The following is a description of a gene set: 267 prognostically relevant Mitochondria-related genes associated with endometrial cancer from publication Lin X, Zheng J, Li Y, Liu L, Liu Q, Lin J, Sun Y (PMID 40354443) Human Gene Set: LIN_ENDOMETRIAL_CANCER_MITOCHONDRIAL_SIGNATURE Mitochondria are essential organelles involved in cell metabolism and are closely linked to various metabolic disorders. In this study, the authors aimed to develop a prognostic model for endometrial cancer (EC) patients based on mitochondria-related genes (MRGs), and to investigate the role of MACC1 in EC. As shown in the graphic summary, the authors retrieved gene expression and clinical data from open-access databases. To construct a predictive signature, the authors applied the Lasso Cox regression algorithm to MRGs. The predictive performance, immune features, and anti-tumor response of the mitochondrial signature was evaluated through multiple algorithms. Additionally, expression levels of key genes were validated using quantitative Real-Time PCR and Western Blot. A total of 2030 MRGs were retrieved, and 267 were found to be prognostically relevant. Eight MRGs MACC1, CMPK2, NDUFAF6, DUSP18, TOMM40L, MT-TP, SAMM50, and MAIP1 were identified to construct a prognostic signature for EC. The MRG signature demonstrated significant associations with drug sensitivity, immune therapy, and immune cell infiltration. Based on comprehensive bioinformatic analysis, MACC1 was identified as the most promising MRG candidate in EC. Systematic experimental validation, including both in vitro and in vivo approaches, demonstrated that MACC1 down-regulation significantly suppressed EC progression, highlighting its potential as a therapeutic target. species: Homo sapiens, and this is the list of marker genes: BCL2A1, TRMT10C, KRAS, SCO2, HSD17B4, IMMT, KIF1B, TIMM50, DUSP18, ARL6IP5, RAC2, ACAD11, PRELID3B, CARS2, MRPL36, HIF3A, MRPL3, SUGCT, TP73 (tumor protein p73), IGF1, RSAD2, MMP9, MX1 (MX dynamin like GTPase 1), NIPSNAP3B, HIP1R, CHCHD3, MXD1, NME3, PSEN1, TLE6, SFXN1, MMP1, CDK1, GLDC, STARD3, YWHAQ, TOMM40L, HSPD1, RNF122, PYURF, MRPL15, TRMT10A, HMGA1 (high mobility group AT-hook 1), COA5, KLK6, NDUFB5, FDXR, PCCB, MLLT11, MAOB, YBEY, MYCBP, TMEM65, AASS, YWHAE, ADH5, OPA1, ANXA1, COX4I2, SAMM50, ELAC2, PECR, SPATA18, TIMM8B, GZMB, BCL2L1, PPIF, ACADM, SPIRE1, MRPS10, POLQ (DNA polymerase theta), NIF3L1, MT-TP, NFKB1, GFM2, PDZD8, FUNDC2, DGAT2 (NCBI Gene Id 84649), DEGS1, POLDIP2, AMT, RAB29, SLC25A44, MRPL37, COX20, BBC3, NLRX1, ATP7B, PLA2G4F, MX2, COX7A1, CYBA, CMC4, ABCG1, GPS2, TP53BP2, COASY, MTFR1L (NCBI Gene Id 56181), BCKDHB, GIMAP8, CYP2D6, CHKB, CHCHD7, FPGS, DHRS7B, HJURP, OCIAD2, ASB9 (NCBI Gene Id 79067), ARMC1, BSG, ATP5F1D, AHCYL1, CEBPA, MT-TT, TDRKH, BHLHA15, OXSM, E2F1, SREBF1, SPAST, ACAD10, ALDH3A2, GRPEL2, WIPI2 (NCBI Gene Id 51623), HK1, ACACB (NCBI Gene Id 32), TNFRSF1A, TP53, MTFR2, ERBB4, PEMT, PPP2R3C, DNA2, BBOX1, BAK1, GTPBP8, PRMT6, GPX4, RAB32, AK4, YWHAB, UNG, CRAT, WASF1, THOP1, ACBD7, ENDOG, NAT8L, NAXE, SIRT3, MAIP1, MACC1, NDUFAF6, TLR3, RNF5, EYA2, CREB3L4, PHYH (phytanoyl-CoA 2-hydroxylase), ALDH18A1, ACSL5, TRAK1, MCAT, NARS2, PTPMT1 (NCBI Gene Id 114971), NDUFA13, SLC25A35, YWHAZ, SLC25A45, TOMM6 (NCBI Gene Id 100188893), STPG1, SLC44A1, URI1, PYCARD, NDUFA6, VWA8, MRPL47, LYPLA1 (lysophospholipase 1), MTFP1, RAB11FIP5, SLC2A4, HSDL2 (hydroxysteroid dehydrogenase like 2), ACLY, DLGAP5, SLC2A1, SUOX, TMEM14A, DNAJC4, HMGCL, HSP90AB1, VASN, GOT2, SQOR, SLC25A23, PRKCE, CHDH, WDR81, POLB, TNFSF10, SFN, CKMT1B, PNPT1, MDH1, MMAA, MTIF2, GCDH, HARS2, PDK1, PRKAB1, MRPL43, NAMPT, MT-TK, CMPK2, CFAP410, NDUFC1, CDC25C, MRPS22, ASS1, DGLUCY, COX16, CDK5RAP1, MT-TQ, METTL8, SND1, SLC25A19, BAG4, MCCC1, MPST, OXNAD1, LYRM9, TST, PLA2G4B, P2RY1, S1PR4, RB1CC1, FMC1, QTRT2, BCL2L11, TMPRSS2, MRPL13, HPS4, GLYATL2, TMEM205, FASTKD3, MGARP, LRPPRC, MTERF3, ATP13A2, COX4I1, DCAKD, GSTZ1, ADAM28, MACROD1, TMEM102, OAS1, GPN1, ALDH2, CPNE3, STARD7, MRPL48, NNT, ME1, FASTKD1, TRAF6, TBL1XR1, SLC11A2, ECI1, NADK2